Given this list of marker genes PCSK1, KIF5C, KIF5A, EXOC5, VAMP2, EXOC6 (exocyst complex component 6), MYO5A, EXOC4 (NCBI Gene Id 60412), EXOC7, RAB27A, STX1A, PCSK2, P4HB, KIF5B, SLC30A8, EXOC3, CPE, EXOC8, INS, EXOC1, MYRIP, ERO1B, SLC30A5, EXOC2, CLTRN (collectrin, amino acid transport regulator), here is a description of the gene set: studied in species Homo sapiens Generation of insulin containing secretory granules from newly synthesized proinsulin in the lumen of the endoplasmic reticulum (ER) involves formation of proinsulin intramolecular disulfide bonds, formation of proinsulin zinc calcium complexes, proteolytic cleavage of proinsulin to yield insulin and C peptide, and translocation of the granules across the cytosol to the plasma membrane (Dodson & Steiner 1998).<br>Transcription of the human insulin gene INS is annotated as part of the pathway “Regulation of gene expression in beta cells” (see reaction ). The preproinsulin mRNA is translated by ribosomes at the rough endoplasmic reticulum (ER) and the preproinsulin enters the secretion pathway by virtue of its signal peptide, which is co-translationally cleaved to yield proinsulin.<br>In the process annotated here, within the ER, three intramolecular disulfide bonds form in proinsulin, mediated by P4HD (PDI1A) and ERO1B proteins. Correctly folded, disulfide-bonded proinsulin then moves via vesicles from the ER to the Golgi Complex where it forms complexes with zinc and calcium.<br>Proinsulin zinc calcium complexes bud in vesicles from the trans Golgi to form immature secretory vesicles (secretory granules) in the cytosol. Within the immature granules, endoproteases PCKS1 and PCKS2 (Prohormone Convertases 1 and 2) cleave proinsulin at two sites and CPE (Carboxypeptidase E) removes additional amino acid residues to yield the cystine bonded A and B chains of mature insulin and the C peptide, which will be secreted with the insulin. The insulin zinc calcium complexes form insoluble crystals within the granule.<br>The insulin containing secretory granules are then translocated across the cytosol to the inner surface of the plasma membrane. Translocation occurs initially by attachment of the granules to Kinesin 1, which motors along microtubules, and then by attachment to Myosin Va, which motors along the microfilaments of the cortical actin network.<br>A pancreatic beta cell contains about 10,000 insulin granules of which about 1,000 are docked at the plasma membrane and 50 are readily releasable in immediate response to stimulation by glucose or other secretogogues. Docking is due to interaction between the Exocyst proteins EXOC3 on the granule membrane and EXOC4 on the plasma membrane. Exocytosis is accomplished by interaction between SNARE type proteins Syntaxin 1A and Syntaxin 4 on the plasma membrane and Synaptobrevin 2/VAMP2 on the granule membrane. Exocytosis is a calcium dependent process due to interaction of the calcium binding membrane protein Synaptotagmin V/IX with the SNARE type proteins. Reactome Pathway: Insulin processing part of: Peptide hormone metabolism